Given this list of marker genes Spint2, Mylk, Mink1, Irf8, Psap, H2az1, Zfand6, Txn1, Scamp2, Ccl17, Snx8, Dapk2, Cyb5r3, Plaat3, Lad1, Syngr2, Efhd2, Slamf7, Stxbp6, Txndc17, Ube2l6, Rabgap1l, Cst3, Gsn, Glipr2, Basp1, here is a description of the gene set: Genes positively differentially expressed in cell type: MigDC (migratory dendritic cell) upon treatment with cytokine: IL-13 in mouse lymph nodes in vivo. Cytokines mediate cell-cell communication in the immune system and represent important therapeutic targets. A myriad of studies have highlighted their central role in immune function, yet we lack a global view of the cellular responses of each immune cell type to each cytokine. To address this gap, the authors created the Immune Dictionary, a compendium of single-cell transcriptomic profiles of more than 17 immune cell types in response to each of 86 cytokines (>1,400 cytokine-cell type combinations) in mouse lymph nodes in vivo. A cytokine-centric view of the dictionary revealed that most cytokines induce highly cell-type-specific responses. For example, the inflammatory cytokine interleukin-1β induces distinct gene programmes in almost every cell type. A cell-type-centric view of the dictionary identified more than 66 cytokine-driven cellular polarization states across immune cell types, including previously uncharacterized states such as an interleukin-18-induced polyfunctional natural killer cell state. studied in species Mus musculus from publication Cui A, Huang T, Li S, Ma A, Pérez JL, Sander C, Keskin DB, Wu CJ, Fraenkel E, Hacohen N (PMID 38057668) Mouse Gene Set: CUI_MIGDC_IL13_RESPONSE_UP